Given this list of marker genes TPPP2, TAC4, TEX101 (NCBI Gene Id 83639), DNAH11, BORCS5 (BLOC-1 related complex subunit 5), TACR1 (NCBI Gene Id 6869), CCDC40, HAP1, ODAD2, CATSPER1, MKKS, TACR2, HDAC6, CYB5D1, TTC21B, RNASE10, CCDC39, PGAM4, FNTA, TRIM46, DRC1, DYNLT2B, RUFY4, APC, BBS2, IRGC, CFAP298, SEMG2, CFAP206, EPPIN, CLXN, RSPH4A, KIF9, LAMP1, FEZ1, BBS1, TTLL6, FNTB, BBS4, NEFH, RUFY3, IQCF1, MAP2, DEFB1, CFAP20, STK11, GAS2L2, TAC1, IGBP1, TAC3, TACR3, SEMG1, ADAM7, CFAP45 (cilia and flagella associated protein 45), CCDC65, DNAAF1, CCR6, TRIM58, PRDM14, CFAP43, CFAP69, here is a description of the gene set: Human Gene Set: GOBP_REGULATION_OF_MICROTUBULE_BASED_MOVEMENT Any process that modulates the rate, frequency, or extent of microtubule-based movement, the movement of organelles, other microtubules and other particles along microtubules, mediated by motor proteins. studied in species Homo sapiens